Given this list of marker genes FOXC2, ACTA2, NOTCH1, GPR4, PDGFB, here is a description of the gene set: Human Gene Set: GOBP_GLOMERULAR_MESANGIAL_CELL_DEVELOPMENT The process whose specific outcome is the progression of a glomerular mesangial cell in the kidney over time, from its formation to the mature structure. species: Homo sapiens